The following is a description of a gene set: Human CD14 positive monocytes were purified from healthy volunteers’ blood and cultured in vitro for 4, 12, 24, 72 hours. While culturing, macrophages were activated alternatively with interleukin-4 (IL-4 100 ng/ml) or classically with interferon-gamma (IFNg 100 ng/ml)+tumor necrosis factor (TNF 50 ng/ml) or left without activation. Simultaneously, macrophages were also treated with vehicle (DMSO:ethanol) or 1mM synthetic PPARg agonist, Rosiglitazone. We used Affymetrix microarrays (U133Plus 2.0) to analyze activation and PPARg-induced gene expression changes. species: Homo sapiens from publication Szanto A, Balint BL, Nagy ZS, Barta E, Dezso B, Pap A, Szeles L, Poliska S, Oros M, Evans RM, Barak Y, Schwabe J, Nagy L (PMID 21093321) Human Gene Set: GSE16385_MONOCYTE_VS_12H_IFNG_TNF_TREATED_MACROPHAGE_DN Genes down-regulated in monocytes (12h) versus macrophages (12h) treated with IFNG and TNF., and this is the list of marker genes: ELOVL1, TPMT (thiopurine S-methyltransferase), POGLUT2, ACE2, GAS2L3, SNX7, GMFG, TTC9C, IMPG1, MRPL24, DIPK2B, B3GAT2, OGFRL1, SERF1A, CKAP2, DPEP3, MYH6, FPR1, NEK7, MS4A6A, TMC4, UNC5D, HPRT1, FAM161A, SEC63, AMZ1, PSMB4, LORICRIN, FBXO8, PSMA3, RAB14, NOCT (nocturnin), GDPD5, MFAP3L, OLFML1, TMEM181, PAX3, SUCO, LGR5 (leucine rich repeat containing G protein-coupled receptor 5), YPEL2, CDHR1, THRA, SAT1, ANAPC4, RAB29, SPRN, HILPDA (NCBI Gene Id 92496), THEM4, PRKAB2, MTFR2, ONECUT1, SENP7, SPATA9, OMA1, PRKRA, SGSH, RASGRF1, DBP, SLC25A20, THEMIS2, CRYZL1, SHTN1, TRIM15, RBP7, KIF1A, P2RY14 (purinergic receptor P2Y14), FAM72A, CLMP, ZBTB3, CDC20, PRKACB, POM121L12, CEP55 (NCBI Gene Id 94765), OR51B2, IAH1, SPCS3, PCSK1 (proprotein convertase subtilisin/kexin type 1), RPAP2, ARHGAP30, C6, NMNAT1, SLC35A1, HACD2, RITA1, LAMC2, AHCYL2, PLA2G4D, PKDREJ, HTRA1, MTPAP, NXPH3, GRN, ITGA7, DNAH11, ERC2, ARHGEF15, HPF1, NMRK1, NDUFA2, CAMKMT, TRIB3, GOLM1, MORF4L1, LONRF2, APOBEC4, WNT1, FAM25C, ZNF354B, FGL1, NUBPL, RTRAF, RAB39B, KLHL30, PEX13, DNMT3B, SBDS (SBDS ribosome maturation factor), MAN2A1, DNTT, MPEG1, CEP43, ANXA1, SDCBP2, WDR54, SOSTDC1, COX6C, PLAAT5, DNAAF10, INSL5, SOD3, PILRA, TTC3, RIBC2, LRRC4, ACOX3, LUC7L3, VSIG10, SPZ1, UPF3B, PLPPR5, PHYHD1, PLCB3, EPS8L1, SCN4A, COL16A1, VKORC1L1, NPC2, CSNK1D, PPP1R1A, GALNT9 (polypeptide N-acetylgalactosaminyltransferase 9), LRFN5, NACC2, WWP1 (NCBI Gene Id 81891), FOXI1, CEP162, RWDD3, CTSE, MYL11, FILIP1L, SLC41A1, KIF26A, SLITRK1, PNPLA1, TEX35, PDC, ADGRB1, HMMR, POLR3K, LASP1, MINDY3, CTLA4, TACR3, CIMIP1, TAL1, FBXL16, SRP54, PXDC1, SLC30A4, NQO1, NHLRC2, OR51E1, AHNAK2, FHIP2B, PSRC1, BCAN, SCG2, P2RX2, C6orf136, IFI30, BCL2L10, FCAMR, PRC1, SCAPER, LIPT1, SCARF1, TEC, PIGQ, LNX1, TMEM273, AIF1, ZMYM3